The following is a description of a gene set: The gene expression program underlying the specification of human cell types is of fundamental interest. The study authors generated human cell atlases of gene expression and chromatin accessibility in fetal tissues. For gene expression, the study authors applied three-level combinatorial indexing to >110 samples representing 15 organs, ultimately profiling ~4 million single cells. The study authors leveraged the literature and other atlases to identify and annotate hundreds of cell types and subtypes, both within and across tissues. Our analyses focused on organ-specific specializations of broadly distributed cell types (such as blood, endothelial, and epithelial), sites of fetal erythropoiesis (which notably included the adrenal gland), and integration with mouse developmental atlases (such as conserved specification of blood cells). These data represent a rich resource for the exploration of in vivo human gene expression in diverse tissues and cell types. species: Homo sapiens Human Gene Set: DESCARTES_FETAL_ADRENAL_CHROMAFFIN_CELLS Marker genes curated from the annotated cluster as represented in the Descartes Human Gene Expression During Development database. from publication Cao J, O'Day DR, Pliner HA, Kingsley PD, Deng M, Daza RM, Zager MA, Aldinger KA, Blecher-Gonen R, Zhang F, Spielmann M, Palis J, Doherty D, Steemers FJ, Glass IA, Trapnell C, Shendure J (PMID 33184181), and this is the list of marker genes: TTC9B, CCND1, PRKAG2-AS1, RYR2, RNU6-457P, MARCHF11, DCLK3, ENSG00000254746, INSRR (insulin receptor related receptor), REEP1, CFAP20DC-AS1, SERTAD4, FAM120A2P, RORB-AS1, KCNG1, ANKFN1, ADCY8, SLCO5A1-AS1, NPY, GAP43, RNU7-99P (RNA, U7 small nuclear 99 pseudogene), HTR3A, KRTAP5-AS1, LINC01561, ENSG00000251216, LINC02607, HIKESHIP1, ST8SIA2, ENSG00000232234, DUSP8, LINC02605, HAND1 (NCBI Gene Id 9421), LINC02066, ELAVL2 (NCBI Gene Id 1993), PIRT, DIRAS1, BRINP2, MAP1B, INSM2, ARHGDIG, LINC02600, SHOX2, NUDT10, ISL1, PEX5L, LINC02525, CAMK2A, AMER3, LINC02897, FAM131B, HECW1-IT1, GAL, LRRTM2, IL7, JPH3, EYA1, HECW1, ONECUT2, SV2C, HMX1, CAVIN4, ALK, FRMPD3, RPH3A, TRIM36, EYA4, TUBB2A, MGC15885, TLX3, HS3ST5, KCNB2, PTCHD1, CREG2, LINC02269, FOXN4, TROAP-AS1, LINC01539, TTLL7-IT1, TMEM132C, FAT3, SLC22A9, AMER2, RBFOX1, LINC02074 (NCBI Gene Id 102723567), PRPH, PLPP4, KCNK10, MARCHF11-DT, TMEFF2, CACNG2-DT, TUBB2B, THAP12P7 (NCBI Gene Id 100422712), LINC01201, ARSF, MAB21L1, NTRK1, BASP1, TMEM196, FAR2P1 (NCBI Gene Id 730024), NRG1-IT3, SPMIP6, RPSAP43, GREM1, SLC6A2, STMN4, CNTFR, ENSG00000225144, TMEM35A, PKIA-AS1, MLLT11, IRX6, SERTAD4-AS1, ENSG00000253726, IGLON5, PTCHD1-AS, CADM3, SPHKAP, SLC44A5, ENTPD3, SCUBE1, TRIM67, PLXNA4, MARK2P3